The following is a description of a gene set: from publication Schaefer CF, Anthony K, Krupa S, Buchoff J, Day M, Hannay T, Buetow KH (PMID 18832364) Human Gene Set: PID_ERB_GENOMIC_PATHWAY Validated nuclear estrogen receptor beta network studied in species Homo sapiens, and this is the list of marker genes: DDX54, ZNF14, NCOA1, C3 (NCBI Gene Id 12266), SMARCE1, SMARCB1, NCOA3, NR0B2, NCOA2, SMARCA4, NR0B1, UBE2M, UBA3, ESR2, NEDD8